Given this list of marker genes Gm40330, Aacs, Ubc, Rabgef1, Gm6139, 4933438B17Rik, Ran, Ncor2, Sumf2, Gm43001, Gm15921, Phkg1, 4930553I04Rik, Gm33347, Gm40331, Cct6a, Kctd7 (potassium channel tetramerisation domain containing 7), Gm15903, 9430087B13Rik, Tyw1, Crcp, Septin14, Vkorc1l1, Zbed5, Snora15, Rflna, Glt1d1, Rimbp2, Chchd2, Gm7774, Tmem132cos, Tpst1, Ndufa12-ps, 1700081B01Rik, Gm24839, Mrps17, Psph, Fzd10os, Sfswap, Gusb, Zfp11, Tmem248, Nupr2, Piwil1, Stx2, 2210412B16Rik, Gm40332, Slc15a4, Fzd10, Gm10382, 1700048F04Rik, Rps16-ps2, Gm22618, A330070K13Rik, 4930572K03Rik, Gm40323, Gm6598, Asl, Adgrd1, Gm32585, Sbds, 4930573I07Rik, Caln1, Gm23245, Dhx37, Scarb1, Tmem132b, Gm42875, Nipsnap2 (NCBI Gene Id 14467), Mmp17, Bri3bp (NCBI Gene Id 76809), Tmem132c, Gm4868, Tmem132d, here is a description of the gene set: studied in species Mus musculus Mouse Gene Set: chr5G1